The following is a description of a gene set: Any process that results in a change in state or activity of a cell (in terms of movement, secretion, enzyme production, gene expression, etc.) as a result of detection of, or exposure to, a hypotonic environment, i.e. an environment with a lower concentration of solutes than the organism or cell. Human Gene Set: GOBP_CELLULAR_HYPOTONIC_RESPONSE studied in species Homo sapiens, and this is the list of marker genes: SLC4A11, TRPV4 (NCBI Gene Id 8098), AQP5, MYLK, FBP1, OXSR1, CLCN2, TSPO, STK39, CAB39, SLC12A6